The following is a description of a gene set: A G protein-coupled receptor signaling pathway that starts with an opsin being activated by a photon, and ending with the light signal being trasmitted through the synapses. The signal can be transmitted via different Galpha subunits types: Go, Gs, Gq, and Gt. studied in species Mus musculus Mouse Gene Set: GOBP_G_PROTEIN_COUPLED_OPSIN_SIGNALING_PATHWAY, and this is the list of marker genes: Pcp2, Aipl1, Gnat1, Grk1, Rho